Given this list of marker genes Dach1, Kcnk2, Ahr, Chek1, Pinx1, Gnl3l, Gja1, Terf1, Pot1a, Dcp2, Trp53, Adipoq, Pif1, Rgn, Nat10, Src, Stn1, Hnrnpc, Cdkn1a, Acd, Tinf2, Hnrnpu, Dusp1, Pot1b, Tent4b, Exosc10, Ankrd1, Dnajc2 (DnaJ heat shock protein family (Hsp40) member C2), Terf2, Ctc1, Niban2, Ten1, Pml, Nppc, here is a description of the gene set: Mouse Gene Set: GOBP_NEGATIVE_REGULATION_OF_DNA_BIOSYNTHETIC_PROCESS Any process that stops, prevents or reduces the frequency, rate or extent of DNA biosynthetic process. species: Mus musculus